Given this list of marker genes RNF213, ADIG, RAB40A, SDR16C5, HSD3B7, SETSIP, RAB40C, FAF2, CHKA, RBP1, TMT1B, NSDHL, SMPD1, RDH10, ANXA2, FABP4, ZW10, PISD, AIFM2, ALOX15, LPCAT1, HSD17B11, DGAT2, ACSL3, PNPLA2, DHRS3, CLDN11, CAV1, G0S2, TSC1, PRPF19, IRAK1, STARD13, FIG4, GIMAP7, C18orf32, ATG2B, AQP7, PLIN3, RAB3GAP1, PNPLA1, BSCL2 (NCBI Gene Id 84753), PITPNM1, VPS13C, EDA, ACSL4, RAB18, OR6C6, ABHD5, TAOK3, AUP1, PLA2G4C, SIGMAR1, LDAF1, TRAF6, RAB7A, PLIN1, VPS13A, CKAP4, EHD1, SET (SET nuclear proto-oncogene), SPAST, HILPDA, LDAH, CIDEA, IRGC, DHRSX, PNPLA4, PNPLA3, TMEM135, PLIN5, LSS, RAP1B, ABHD4, UBE2G2, APOB, RAB5C, CES1, FAAH2, LPCAT2, TMT1A, PNPLA5, ALDH3B2, CIDEC, CYB5R3, ZFYVE1 (NCBI Gene Id 57694), BCAP31, LMLN, CTDNEP1, HSD17B13, OSBPL2, PNPLA7, ATG2A, CIDEB, SCCPDH, GIMAP2, VCP, SYNGR2, LIPE, AQP10, PLIN4, CLSTN3, SPART, RSAD2 (NCBI Gene Id 91543), GBF1, GAPDH, PLIN2, here is a description of the gene set: species: Homo sapiens Human Gene Set: GOCC_LIPID_DROPLET An intracellular non-membrane-bounded organelle comprising a matrix of coalesced lipids surrounded by a phospholipid monolayer. May include associated proteins.